The following is a description of a gene set: species: Mus musculus Enables the transfer of a peptide from one side of a membrane to the other. Mouse Gene Set: GOMF_PEPTIDE_TRANSMEMBRANE_TRANSPORTER_ACTIVITY, and this is the list of marker genes: Tap2, Slc15a1, Slc15a2, Abcb9, Slc15a4, Tap1